The following is a description of a gene set: Human Gene Set: GOBP_NEGATIVE_REGULATION_OF_NUCLEAR_RECEPTOR_MEDIATED_GLUCOCORTICOID_SIGNALING_PATHWAY Any process that stops, prevents or reduces the frequency, rate or extent of nuclear receptor-mediated glucocorticoid signaling pathway. species: Homo sapiens, and this is the list of marker genes: CLOCK, CREBRF, PHB1, CRY2, PER1, BMAL1, CRY1